The following is a description of a gene set: Mouse Gene Set: GOBP_NEGATIVE_REGULATION_OF_CALCINEURIN_MEDIATED_SIGNALING studied in species Mus musculus Any process that stops, prevents or reduces the frequency, rate or extent of calcineurin-mediated signaling., and this is the list of marker genes: Rcan1, Gsk3b, Mapk7, Myoz2, Fhl2, Homer3, Myoz1, Cmya5, Mtor, Prnp, Tbc1d10c (NCBI Gene Id 74822), Atp2b4, Homer2, Dyrk2, Actn3, Chp1